The following is a description of a gene set: studied in species Mus musculus Any process that activates or increases the frequency, rate or extent of differentiation of CD4-positive, CD25-positive, alpha-beta regulatory T cells. Mouse Gene Set: GOBP_POSITIVE_REGULATION_OF_CD4_POSITIVE_CD25_POSITIVE_ALPHA_BETA_REGULATORY_T_CELL_DIFFERENTIATION, and this is the list of marker genes: H2-Ea, Foxp3, Klhl25, Ifng, Gimap5, Gimap3, Il2rg